The following is a description of a gene set: Mouse Gene Set: GOBP_N_TERMINAL_PROTEIN_LIPIDATION studied in species Mus musculus The covalent attachment of a lipid group to the amino terminus of a protein., and this is the list of marker genes: Hhat (hedgehog acyltransferase), Nmt2, Ppm1a, Ppm1b, Map6d1, Nmt1, Hhatl